Given this list of marker genes Hras, Mapk1 (NCBI Gene Id 98012), Pdpk1 (3-phosphoinositide dependent protein kinase 1), Kras, Prkcz (NCBI Gene Id 97193), here is a description of the gene set: Estrogen-stimulated signaling through PRKCZ Mouse Gene Set: REACTOME_ESTROGEN_STIMULATED_SIGNALING_THROUGH_PRKCZ species: Mus musculus